The following is a description of a gene set: studied in species Mus musculus The aggregation, arrangement and bonding together of the mitochondrial ribosome and of its subunits. Mouse Gene Set: GOBP_MITOCHONDRIAL_RIBOSOME_ASSEMBLY, and this is the list of marker genes: Noa1, Rcc1l, Mterf3, Mterf4, Ngrn (neugrin, neurite outgrowth associated), Mpv17l2, Fastkd2, Mrps2, Mcat, Dhx30, Mpv17l, Ddx28, Mettl17, Mrm2